Given this list of marker genes Aspm, Pafah1b1, Akap9, Gpsm2, Tbccd1 (TBCC domain containing 1), Spout1, here is a description of the gene set: Mouse Gene Set: GOBP_MAINTENANCE_OF_CENTROSOME_LOCATION Any process in which a centrosome is maintained in a specific location within a cell and prevented from moving elsewhere. studied in species Mus musculus